The following is a description of a gene set: from publication Chen Y, Wang X (PMID 31504780) Genes predicted to be targets of miRBase v22 microRNA hsa-miR-1910-3p in miRDB v6.0 with MirTarget v4 prediction scores > 80 (high confidence targets). Human Gene Set: MIR1910_3P species: Homo sapiens, and this is the list of marker genes: ACAA2, MAP2, ENSG00000187186 (NCBI Gene Id 731532), BLMH, SIRPB1, SLAIN2, C1GALT1, MTF1, PAK1, NKTR, DUOX1, UST, TRAF3, WIPF3, IL17A (interleukin 17A), NEXMIF, LZTS1, TRIM44, SMARCAD1, CASP7, GPR107, USP53, FAM83B, RCOR1, IGFBP3, ZIC3, SOX6, ZNF652, RBFOX2, IGDCC4, PLXDC2, APBB2, RBM39 (NCBI Gene Id 9584), YWHAB, CMTM7, GOLPH3, CRIPT, FXYD6, RBM3 (RNA binding motif protein 3), PPP1R13L, STOM, NCOA3, SMAD2, CUL5, DCP1B, FRAS1, PACS1, BTBD10, SV2B, AFF3, TTPAL, TMEM154, SCML4 (NCBI Gene Id 256380), NUFIP1, AMPH, AFF4, IPO8, CAMSAP2, DPY19L1, CRKL, MBP, WIPF2, SPOCK2 (SPARC (osteonectin), cwcv and kazal like domains proteoglycan 2), ZC2HC1C, STIM2, KIAA0930, BCAS1, RAB3C, GYS2 (glycogen synthase 2), ADGRL2, AIF1L, SLC9A6 (solute carrier family 9 member A6), OLFM3, TAF9B, RBMXL1, ARHGAP1, STRN, ACSL1, N4BP1, ARRDC4, COX15, JPH3, CEP85, C1orf74, OLFM2, DPF2, LASP1, ST8SIA2, SRPRA, NECTIN1, AKAP6, TNS1, HMGXB4, PDS5A, LMBR1L, MMD, ATP8A1, ME1, ZZZ3, GSS, ME2, OSBPL9, SETD9, MAP3K20, ZMAT2, FIZ1, RCC1L, ZC4H2, MAP3K9, TIAL1, TMX3, CDKL5, TECPR2, PAPPA, SMIM14, NECTIN3, PLXNA2, BMP6, SUMO3, EML6, SPTSSB, KCNT2, DESI2, ERAP1, ANKS1B, KIF1B, SV2C, ULK2, PPP1R3D, NT5E, SERPINB8, ZBTB20, CLEC3A, VAMP7, VPS54, CCND2, ASAP1 (ArfGAP with SH3 domain, ankyrin repeat and PH domain 1), MED15, RNF4, LIMCH1, HMBOX1, BCL11B, CEP350, PLP1, STMN2, MYO1D, ARID1B, KCND3, CYP8B1, SLC66A1 (NCBI Gene Id 54896), MYLK3, KPNA3, POT1, REEP1 (NCBI Gene Id 65055), FAM91A1, FAM8A1, ARHGEF6, EVI5 (ecotropic viral integration site 5), TF, IKZF1, NUP153, EGR2, SH2B3, SCUBE3, KIF3B, ATP2B3, TMEM121B, ADNP, TP53INP2, KHDRBS1, PPP3CA, WASF2, CNOT4, PARVB (NCBI Gene Id 29780), MYO1C, DESI1, USP46, ALS2, HPCAL4, TENT4A, INHA, KRT73, DDX50, ZFHX2, MB21D2, SPRY3